The following is a description of a gene set: A protein ubiquitination process in which ubiquitin monomers are attached to a protein, and then ubiquitin polymers are formed by linkages between lysine residues at position 11 of the ubiquitin monomers. K11-linked polyubiquitination targets the substrate protein for degradation. The anaphase-promoting complex promotes the degradation of mitotic regulators by assembling K11-linked polyubiquitin chains. Mouse Gene Set: GOBP_PROTEIN_K11_LINKED_UBIQUITINATION species: Mus musculus, and this is the list of marker genes: Cdc26, Ube2d2b, Anapc4, Anapc1, Rnf26, Ube2b, Anapc13, Rnf115, Anapc10, Ube2srt, Anapc16, Anapc7, Arel1, Anapc15-ps, Anapc5, Ube2c, Cdc27, Ubr5, Asb11, Anapc2, Ube2w, Ubr4, Ube2l3, Cdc16, Ube2s, Prkn, Ube2e3, Ube2t, Cdc23, Anapc15, Ube2h, Rnf26rt, Anapc11, Ube2e2, Trim26, Ube2d3, Ube2a, Rnf4